Given this list of marker genes SMG5, NAF1, TCP1, PARP3, ATR, SLX1B, TERF2, HNRNPA2B1, HSP90AA1, SLX1A, CTC1, TEN1, CTNNB1, TERF1, HNRNPC, RTEL1 (regulator of telomere elongation helicase 1), ACD, HNRNPD, TNKS2, PML, NAT10, CCT5, PARN, CCT2, DHX36, TP53, CCT4, EXOSC10, FBXO4, SLX4, DCP2, MCRS1, XRN1, CCT3, PIF1, CCT6A, PINX1, STN1, ERCC4, SMG6, CCT7, TENT4B, ATM, CCT8, WRAP53, HNRNPA1, HNRNPU, TNKS, PARP1, GNL3L, TINF2, DKC1, POT1, PTGES3, here is a description of the gene set: Any process that modulates the frequency, rate or extent of telomere maintenance via telomere lengthening. Human Gene Set: GOBP_REGULATION_OF_TELOMERE_MAINTENANCE_VIA_TELOMERE_LENGTHENING species: Homo sapiens